The following is a description of a gene set: A process that converts synaptic vesicles to a state of competence for calcium triggered fusion with the active zone membrane by bringing the two membranes into very close proximity. Priming typically (but not always) occurs after docking. Primed vesicles are also capable of spontaneously fusing with the active zone membrane. species: Mus musculus Mouse Gene Set: GOBP_SYNAPTIC_VESICLE_PRIMING, and this is the list of marker genes: Rims2, Unc13a, Stx1a, Napb, Rims3, Cadps2, Rab3gap1, Vamp1, Stxbp1, Rims1, Snca, Rab3a, Syngr3, Cadps, Brsk1, Erc2, Unc13c, Snap23, Otof, Synj1, Syp, Stx1b, Sv2a, Rph3a (NCBI Gene Id 70216), Napa, Erc1, Stxbp5, Unc13b, Osbpl2, Efr3a, Snap29, Snap25, Snap47